The following is a description of a gene set: Neighborhood of PFN1 profilin 1 in the GCM expression compendium Human Gene Set: GCM_PFN1 species: Homo sapiens Neighborhood of PFN1, and this is the list of marker genes: CSNK2B, HNRNPL, CBFB, RPS24, HCLS1, MCM6, OAZ1, RPL21, HNRNPD, NONO, SRSF9, NDUFA12, PSME1, CFL1, HNRNPM, HDAC1, ILF2, PSMD8, RPL19, SET, ATP5F1B, PFN1, MSN, RPL29 (ribosomal protein L29), PSMB2, PTMA, SNRPD2, ARHGEF1, SNRPD3, SNRPA, PPP4C, RPL14, DRAP1, RPS5, RPL27, ARHGDIB, ATP5F1C, CLIC1, RHOA, PPIA, RPS8, H2AZ1, RPS7 (ribosomal protein S7), APRT, NCL, PRMT1, APEX1, SLC25A3, RPS19, EIF4A1, GPSM3